Given this list of marker genes STK36, GLI3, RBBP4, KIF3A, PRKACA, PTCH1, CREBBP, SSPOP, SIN3A, GNAI1, CSNK1G3 (casein kinase 1 gamma 3), MAP2K1, IFT172, GNAO1, ARRB2, SMO, GNAI2, GNG2, XPO1, IFT88, GLI1, SHH, HDAC1, PIAS1, CSNK1G2 (casein kinase 1 gamma 2), GNAZ (NCBI Gene Id 2781), FOXA2 (forkhead box A2), CSNK1D, SUFU, SAP18, MTSS1, RAB23 (NCBI Gene Id 64438), GNAI3, GSK3B, GNB1, SIN3B, CSNK1A1, CSNK1G1, CSNK1E, LGALS3, PRKCD, HDAC2, AKT1, FBXW11 (F-box and WD repeat domain containing 11), RBBP7, SAP30, GLI2, SPOP, here is a description of the gene set: Human Gene Set: PID_HEDGEHOG_GLI_PATHWAY Hedgehog signaling events mediated by Gli proteins species: Homo sapiens from publication Schaefer CF, Anthony K, Krupa S, Buchoff J, Day M, Hannay T, Buetow KH (PMID 18832364)